Given this list of marker genes LYSET, SLC38A3, CCIN, OR6A2, EAF1, REEP5, CR1, MUC13, PCDHB1, FUT6, EPDR1, VWA3A, CTSE, DSCR4, COL14A1, ABCA4, SI, PRAME (NCBI Gene Id 4136), EPHA7, PLEK2, MGAT4C, HEPH, OR51F2, ANKS1B, SPRED1, LBP, RAB9BP1, OSBPL7, MAGEB6 (MAGE family member B6), TTBK2, PDE2A, LINC00596, CFAP206, NOX1, TRPM3, CD2, GNAT1, TNFSF18, NPSR1-AS1, PTGFR, CARTPT, ATP2B4, CRYM, TLR3, MUC4, LINC01699, KRTAP19-8, SPMIP9, ARG1, AVPR1B, NPY6R, CD34, RTL3, CD22, DKK4, KCNK9, CLEC9A, ITIH1, TSPAN14, UNC5B, OR2T8, OR2V2, PCYT1B, RNASE8, HIC2, TMEM244, CEACAM8, SLC17A2, C1orf220, PLEKHG4, ACSM1, B3GNT6, CEACAM1, CELSR2, PPP1R2C, OLFM3, CCDC149, OR51V1, KRT2, ADCY7, OR52L1, ANKRD55, FAM78B, SCGB1D4, DCX, PON1, OGFRL1, SLITRK4, PCDHB16, ART3, ASB11, THAP5, CHRNB2, SNORA70F, OR13C5, ARAFP2 (NCBI Gene Id 7970), TSPAN17, SAA4, THEMIS2, SNRPD2P2, PRICKLE2, GADL1 (glutamate decarboxylase like 1), LINC02912, CITED1, SLC22A7, TIGD1, TMC4, CCDC87, CCNQP1, OASL, TAS2R39, LINC01567, ANGPTL5, KRTAP11-1, YAP1, SMIM5, LINC01940, SNORD114-2, SLC1A2, DTNA, TSSK3, TUSC1, TRIM42, ACY3, FZD1, CNIH2, LUM, SCGN, OR12D2, RGR, DCLK2, ILDR1, SLIT2, ITK, DHX16, ZNF527, PI4KA, MGRN1, SNORA70D, LIN7B, ARHGAP4, ARL14, PRND, CFAP61, NPAT, SLC35G3, CX3CR1, PSG3, OR4K15, OR51B5, GABRA6, MIR429, PLG, MLLT3, MIR203A (NCBI Gene Id 406986), WNK1, OR4L1, SLC2A6, FAM86C2P, OR2D2, DENND4B, OR10A4, CD300LD-AS1, CNGB1, CAV1, GPR132, CHRNA3, TPM4, DIP2A, SEM1, BCL11A, CD163L1, SCARNA14 (small Cajal body-specific RNA 14), PEBP4, VSIR, ABHD17C, LINC01559, CTSC, KRTAP5-9, PPFIA2, PRSS8, LCN1P1, ADAM21, MASP1, CIB3, KCNA10, LMAN1L, KRT14, SEMG1, C3P1, OR8K3, FUNDC2, MSMB, SERTAD4, ARID1A, here is a description of the gene set: Genes down-regulated in dendritic cells: diphenyleneiodonium (DPI) versus DPI and 2,4-dinitrofluorobenzene (DNFB). species: Homo sapiens from publication Miyazawa M, Takashima A (PMID 22974541) Identification of ROS induced genes on dendritic cells Dendritic cells were incubated for 15 min with or without a ROS inhibitor (DPI), washed extensively and incubated for 30 min with a chemical allergen (DNFB), hydrogen peroxide, and vehicle alone in HBSS containing DPI or vehicle. After washed extensively, the samples were post-incubated for 5.5 h with DNFB, hydrogen peroxide, or vehicle in complete culture medium containing DPI or vehicle. Human Gene Set: GSE20727_ROS_INH_VS_ROS_INH_AND_DNFB_ALLERGEN_TREATED_DC_DN